Given this list of marker genes Kdr, Fxr1, Fmr1, Nptn, Bdnf, Kit, Shank3, Ephb2, Grm5, Neurl1a (NCBI Gene Id 80633), Fxr2, here is a description of the gene set: Mouse Gene Set: GOBP_POSITIVE_REGULATION_OF_LONG_TERM_NEURONAL_SYNAPTIC_PLASTICITY A process that increases long-term neuronal synaptic plasticity, the ability of neuronal synapses to change long-term as circumstances require. Long-term neuronal synaptic plasticity generally involves increase or decrease in actual synapse numbers. studied in species Mus musculus